Given this list of marker genes Galt, Galk1, Gale, Galm, here is a description of the gene set: Reactome Pathway: Galactose catabolism part of: Metabolism of carbohydrates and carbohydrate derivatives species: Mus musculus This event has been computationally inferred from an event that has been demonstrated in another species.<p>The inference is based on the homology mapping from PANTHER. Briefly, reactions for which all involved PhysicalEntities (in input, output and catalyst) have a mapped orthologue/paralogue (for complexes at least 75% of components must have a mapping) are inferred to the other species. electronically inferred by orthology from the curated human pathway